Given this list of marker genes ITGB6, ITGB8, ITGB7, VCAM1, FN1, CCN1, PLAU, VTN, EDIL3, ITGB5, ITGA4 (NCBI Gene Id 3676), ITGAV, FBN1, SDC1, MADCAM1, TGFBR1, PLAUR, here is a description of the gene set: from publication Schaefer CF, Anthony K, Krupa S, Buchoff J, Day M, Hannay T, Buetow KH (PMID 18832364) Beta5 beta6 beta7 and beta8 integrin cell surface interactions species: Homo sapiens Human Gene Set: PID_INTEGRIN5_PATHWAY